The following is a description of a gene set: Human Gene Set: GOBP_GLUTATHIONE_TRANSMEMBRANE_TRANSPORT studied in species Homo sapiens A process in which glutathione is transported across a membrane., and this is the list of marker genes: SLC25A39, GJA1, SLC13A3, ABCC1, ABCC5, SLC7A11, SLC25A40, ABCC4